The following is a description of a gene set: Human Gene Set: GSE40274_CTRL_VS_XBP1_TRANSDUCED_ACTIVATED_CD4_TCELL_DN studied in species Homo sapiens Genes down-regulated in CD4 T conv: control versus over-expression of XBP1. from publication Fu W, Ergun A, Lu T, Hill JA, Haxhinasto S, Fassett MS, Gazit R, Adoro S, Glimcher L, Chan S, Kastner P, Rossi D, Collins JJ, Mathis D, Benoist C (PMID 22961053) The transcription factor FoxP3 partakes dominantly in the specification and function of FoxP3+ CD4+ T regulatory cells (Tregs), but is neither strictly necessary nor sufficient to determine the characteristic Treg transcriptional signature. Computational network inference and experimental testing assessed the contribution of several other transcription factors (TFs). Enforced expression of Helios or Xbp1 elicited specific signatures, but Eos, Irf4, Satb1, Lef1 and Gata1 elicited exactly the same outcome, synergizing with FoxP3 to activate most of the Treg signature, including key TFs, and enhancing FoxP3 occupancy at its genomic targets. Conversely, the Treg signature was robust to inactivation of any single cofactor. A redundant genetic switch thus locks-in the Treg phenotype, a model which accounts for several aspects of Treg physiology, differentiation and stability., and this is the list of marker genes: RNF128, CLEC4E, DGKH, ZC3HC1, EIF3A, RMDN3, JAGN1, GTF2H4, PDSS1, AURKA, TMEM147, SERP2, TRNAU1AP, MAST2, MEP1A (NCBI Gene Id 4224), PCBP4, PSAT1, ELOVL1, EIF2B1, PUS1, THOC5, GUK1, MASTL, TARBP2, YBX3, HMGN2P6, TENT5C, CTPS1, PMM1, IL12B, VAV3, TOMM20, LARGE2, BCKDK, PSME3, GRHL1, NUBP1, TIGD3, NMT1, NOL9, TWSG1, FTSJ3, SF3B5, PSMA5, IQCG (NCBI Gene Id 84223), TMEM11, POP1 (NCBI Gene Id 23044), FGF12, LSM4, LCMT1 (NCBI Gene Id 51628), GART, ADSS2, EXOSC7, PLK3 (polo like kinase 3), TNFAIP1, CBY1, CENPH, GFI1 (NCBI Gene Id 2672, growth factor independent 1 transcriptional repressor), MZT2B, PFKL, IDE, TIMM13, NUP133, PUS7, LYAR, EIF3I, CSTF2, SCX, PSMA3, MLF2, CSDC2, NDUFA10, SNORA2C, SPC25, PLK1, FIGNL1, UTP20, DKC1, MRPS18B, CEP57, TRIB1, RPS2, TAF9, TMEM70, TRMT61A, PSME1, SPC24, ZMYND19, SRSF1, AHSA1, KIF18B, GMPR, UQCRC1, TICAM2, FOXD4, B4GALT5, EFTUD2, HDAC3, ST13, SULT4A1, CNPY2, SDF2L1, BATF, HCFC1 (NCBI Gene Id 8267), ORC6, TMEM42, NCAPD2, LIPT2, DBT, KRTCAP3, PPP5C, IFNG, SEC13, VCP, PRDX1, GUSB, KSR2, PSMD14, NUDT18, NPHP1, CCNB3, SCFD2, MRPS7, SDHD, IGF2BP3, TBL3, DYNC2I2, OLA1, KARS1, IPO11 (NCBI Gene Id 51194), MPC1, TTK (TTK protein kinase), PDIA6, UMPS, KBTBD13, MCM8, TMEM161A, SETD6, MRFAP1, CPNE9, RBM15B, TXLNB, EIF6, LRRC58, FANCD2, WDHD1, CHKA, HMGN3, TARBP1, RTN4RL2, MTHFD1, PRMT5 (protein arginine methyltransferase 5), YARS1, GPATCH4, MRPL52, RENBP, SPATA7, KPNB1, OXCT1, SNRPA1, PSMC2, HNRNPA3, DSC1, EIF3H, PGAM1